Given this list of marker genes IDO1, SDHB, APRT, SHMT1, PANK1, VPS9D1, MT-ND2, NDUFB11, PFAS, MTHFD2L, ACSBG1, GUCY2F, ACSL3, NME1, IDH2, STOML2, DCK, MTHFD1, NDUFA9, PRPS2, GUCY2D, PDK3 (pyruvate dehydrogenase kinase 3), ADSS2, MMUT, PNP, PDHA1, KYNU, NMRK1, DGUOK, ELOVL3, PDHA2, DIP2A, NME3, ATP5MC2, ATPSCKMT, PANK2, MT-ATP6, NDUFS3, NME4, LIPA, PPT2, MT-ND1, NDUFS4, NPR2, ATP5PO, CBR4, HSD17B12, NPR1 (natriuretic peptide receptor 1), UQCC3, IMPDH2, ATP5F1B, ADCY8, GMPS, ATP5MF, ADSS1, MT-ND5 (mitochondrially encoded NADH:ubiquinone oxidoreductase core subunit 5), PID1, NPPC, PPT1, ATP5ME, MT-ND4, DCAKD, PRPS1L1, SDHC, MTAP, ACSF3, NAMPT, ATP5PF, MIR675, NME9, ADCY1, ADCY4, NME5, NDUFV2, NMRK2, NADK, NDUFB1, NUDT2, NDUFAB1, ACSBG2, DMAC2L, MPC2, ADCY3, ACSL6 (NCBI Gene Id 56972), PDHX, RD3, PANK4, ACSS1, FAM3A, AFMID, TAFAZZIN, NDUFV3, NME6, NME2, NMNAT1, IMPDH1, ADCY6, TGFB1, ADCY5, NPPB, SPHK2, ACACA, KMO, AK2, GUK1, AK5, ACMSD, NDUFC2, GUCY2C, PAPSS2, PPARA, NDUFB7, PRKN, SNCA, PAICS, ATP5IF1, ACAT1, ELOVL4, COX11, NDUFS5, NDUFS2, NPPA, SLC4A7, MAPDA, ADCY7, TECR, ENO1, ACSL5, NDUFA5, NDUFA11, NDUFC1, MT-ND6, ATIC, ADCY9, PARP1, ACOT7, ELOVL2, AMPD1, AK3, ADK, ADCY10, ATP5MC3, AMPD3, ACLY, LETMD1, ATP5MK, ACSL4, ALDOA, ANTKMT, ACACB, ELOVL1, NDUFV1, COASY, ATP6V0C, NMNAT3, MLYCD, ADCY2, NDUFA10, ATP5MJ, NMNAT2, ASPDH, NDUFB4, NAPRT, HACD2, ATP5F1E, NDUFA3, PRKAG2, GCDH, NDUFB8, PDK1 (pyruvate dehydrogenase kinase 1), AMPD2, NME2P1, PDK4, ATP5PB, NDUFB5, ATP5F1EP2, PRTFDC1, PANK3, NT5E, NDUFA2, NDUFB9, VCP, HPRT1, ATP5MG, AK1, ATP5F1A, SLC25A13, ATP5MGL, ATP5PD, ATP5MC1, NADSYN1, TREM2, PAPSS1, GUCY1A1, NDUFS8, FASN, NDUFA7, DLD, PRPS1, ELOVL5, BCKDK, ATP5F1D, QPRT, MAP2K1, PINK1, STAT3, MT-ND3, DLAT, NDUFA1, IDO2, PRPSAP1, ELOVL7, HAAO, PGK1, PDHB, PPCS, DNAJC30, NDUFS7, PPCDC, SDHA, HTD2, NME7 (NCBI Gene Id 29922), NDUFA8 (NCBI Gene Id 4702), AK4, TPK1, IL4, NDUFS1, NDUFB2, PRPSAP2, NDUFB3, PDK2, NDUFS6, ELOVL6, HACD1, LDHC, SDHD, PPAT, ACSL1, NDUFB6, PGM2, NDUFA6, ACSS2, ADSL, NDUFA13, GUCY1B1, ADA2, GUCY1A2, SLC27A2, NDUFB10, NADK2, GUCA1ANB-GUCA1A, MT-ATP8, TMSB4X, MT-ND4L, GUCA1A, GART (phosphoribosylglycinamide formyltransferase, phosphoribosylglycinamide synthetase, phosphoribosylaminoimidazole synthetase), ADA, ATP5F1C, NDUFA12, here is a description of the gene set: Human Gene Set: GOBP_PURINE_CONTAINING_COMPOUND_BIOSYNTHETIC_PROCESS species: Homo sapiens The chemical reactions and pathways resulting in the formation of a purine-containing compound, i.e. any compound that contains purine or a formal derivative thereof.